Given this list of marker genes DARS1, GARS1, CARS1, KARS1, EEF1E1, PPA1, QARS1, MARS1, YARS1, LARS1, NARS1, AARS1, EPRS1, AIMP1, FARSB, FARSA, WARS1, TARS1, VARS1, RARS1, AIMP2, SARS1 (NCBI Gene Id 6301), IARS1, HARS1, here is a description of the gene set: studied in species Homo sapiens Human Gene Set: REACTOME_CYTOSOLIC_TRNA_AMINOACYLATION Cytosolic tRNA aminoacylation